The following is a description of a gene set: Cross-presentation of particulate exogenous antigens (phagosomes) species: Homo sapiens Human Gene Set: REACTOME_CROSS_PRESENTATION_OF_PARTICULATE_EXOGENOUS_ANTIGENS_PHAGOSOMES, and this is the list of marker genes: NCF4, ITGB5, ITGAV, NCF1, CYBA, NCF2, CD36, CYBB